The following is a description of a gene set: studied in species Homo sapiens Hypoplasia of the corpus callosum Underdevelopment of the corpus callosum. Human Gene Set: HP_HYPOPLASIA_OF_THE_CORPUS_CALLOSUM, and this is the list of marker genes: EXOC8, MINPP1, MT-CO3, SLC5A6, NAE1, TBCK, MT-CO1, SOX2, GFER, GLI3, UNC80, ALX4, SLC25A24, CEP290, CTNNB1, SETD2, PUF60, ZBTB20, UBE3B, RMND1, TRMT10A, WLS, ASNS, TREM2 (NCBI Gene Id 54209), RALGAPA1, NF1, KCNT1, PUS3, ARID1B, PRUNE1, RNASEH2C, SETBP1, TMTC3, EXOC7, FANCB, TUBA1A, PDHX, RNASEH2A, MT-ND6, EXTL3, KIF14, YARS1, TP73, CLP1, OSGEP, ADAT3, WDR73, SAMHD1, TSEN54, WDR81, DYNC1H1, NANS, TUBB2B, EHMT1 (euchromatic histone lysine methyltransferase 1), MRPS22, C2CD3, CSPP1, EMC1, RNF13, NALCN, CACNA1I, SH3PXD2B, GBA1, SIX6, CYP2U1, ZFX, NADK2, AP4B1, TRIM8, SNF8, PIGQ, VWA3B, GLRX5, TRAPPC9, CNOT3, DPAGT1, KIAA0753, IFT52, PSAT1, WDR62, UBTF, AP4S1, WDR45B, LNPK, AFG2A, YIF1B, REPS1, ZNF148 (NCBI Gene Id 7707), ZNF462, PRPS1, TBC1D20, EIF2AK2, ZMIZ1, YY1, POU3F3 (POU class 3 homeobox 3), RAB3GAP1, AFG2B, VPS50, AIFM1, TAF1, DHCR7, CDKL5, PPFIBP1, PI4K2A, FDXR (ferredoxin reductase), RTTN, GCSH, PSAP, CUL4B, PDHB, KIF26A, KMT2D, RB1, UBA5, DARS2 (NCBI Gene Id 55157), TGFB1, GLYCTK (glycerate kinase), MT-TS2, ASXL1, BRF1, FA2H, ATL1, SPG21, AIMP2, FBXW11, AMPD2, CACNA2D1, ACBD6, KCNA1, HPDL, APC2, MAPKAPK5, HACE1, MED12L, CTNNA2, RNU4ATAC, RSPRY1, MOCS1, SLC35B2, MAF (MAF bZIP transcription factor), NFIX, DDX3X, FDFT1, CNTNAP1, KIF5A, RERE, RNU4-2, SCN2A, ZEB2, GRIN1, HK1, GBA2, NR2F1, TBCE, AP4E1 (NCBI Gene Id 23431), PGAP1, EXOSC1 (exosome component 1), PPP1R15B, MT-TL1, CDK13, SLC4A10, TRAPPC6B, DIAPH1, RNU7-1, RAC1 (NCBI Gene Id 5879), ATP6V1A, NUP188, DARS1, COG6, FRMPD4, ARFGEF2, ADARB1, TAF2, KMT2C, TUBGCP2, NHLRC2, SIN3A, TMX2, IGF1R, USP9X (ubiquitin specific peptidase 9 X-linked), KATNB1, PIGU, KCNQ2, EPRS1, PAH, COG2, TOE1, RAI1, USP7, WBP4, SLC6A9, EARS2, KDM5A, SMARCE1, AXIN1, KIAA0586, DDHD2, PCNT (NCBI Gene Id 9346), NT5C2, TMEM106B (NCBI Gene Id 54664), QARS1, ALG2, ZFR, KAT8, ARHGAP31, AKT3, DCX, SHOC2, IFT27, SVBP, SRPX2, SEPSECS, GNAO1, MAP1B, FANCD2, SON, TECPR2 (tectonin beta-propeller repeat containing 2, NCBI Gene Id 9895), PHGDH, GPSM2, SLC1A4, BCOR, KDM6A, PCGF2, PTPN23, VPS53, ARX, FAT4, VPS51, PIK3R2, GFM2 (GTP dependent ribosome recycling factor mitochondrial 2), GJC2, AP3B2, COASY, MTRFR, KCNT2, MT-CO2, POGZ, RUSC2, SPTAN1, ADNP, IFT140, PARS2, EBP, MT-TW, SMG9, HIVEP2, MFSD2A, PDE6D, KIFBP (kinesin family binding protein), CEP120, YWHAE, NONO, NKX6-2, HS2ST1, OTUD5, FRA10AC1, FIG4, EXOC2, CLCN4, PLAA, TOGARAM1, PCLO, PIGG, WAC, COPB2, MED25, COX7B, LSS, KIF7, PNKP, SLC6A8 (NCBI Gene Id 6535), SCN3A, DNA2, GRIN2A, TRAPPC14, HUWE1, VARS1, SNIP1, MTOR, POMT2, GRIA3, KIF5C (kinesin family member 5C), MT-TH, RAB3GAP2, FGFR1, NARS1, VPS11, KIDINS220, GFM1, NARS2, TREX1, EIF2S3, ZFYVE26, MT-ND1, CCDC174, MEF2C, ERLIN2, STAMBP, NFIA, BRAT1, SLC32A1, NOVA2, MOCS2, SSR4, ZNHIT3, ATP9A, GRIA4, SPG11, PITX1, MT-ND5, PAFAH1B1, WDR26, MID1, SLC1A2, SCN1B, DCHS1, KDM5B, MAPRE2, ARSI, POLR2A, POLR3B, PAX6, TSEN2, POLG2, NEXMIF, LARGE1, UGP2, CARS1, MT-TQ, PLPBP, ERMARD, PPP1R21, PDHA1, LMNB1, GRM7, ADAR, NFU1, TTI2, PIGA, AP5Z1, KDM1A, AHCY, HNRNPK, PRMT7, PIGP, GAD1, FBXL4, MACF1, TUBB2A, NEUROD2, TMEM237, TMCO1, GOT2, CNP, ACTL6B, IBA57, TARS2, RARS1, RAB18, MTHFS, GMPPB, RNASEH2B, HIC1, ASXL3, SHMT2, RHOBTB2, CCDC88A, SCAF4, ASPM, TUBB3 (tubulin beta 3 class III), AP4M1, NRROS, FGFR3, TSEN34, MYCN, PIGB, PPP2R1A, AHDC1, FKRP, IFIH1, EXOSC8, ACO2 (NCBI Gene Id 50), UBE3A, TCF4 (NCBI Gene Id 6925), PLCB4, CRIPT, HSD17B4, LSM11, OCA2, CRPPA, ALDH6A1, SACS, TUBB (NCBI Gene Id 95295, tubulin beta class I), KIF2A, TBCD, GABRB1, MAPK8IP3, WWOX, RAC3, MT-TF, CARS2, TYROBP, POLR1C, MT-ND4, CASK, DOCK7, TSEN15, PGAP2, ALG12, ARNT2, SOX3 (SRY-box transcription factor 3), GABRA5, POLR3GL, BUB1B, SLC25A22, FKTN, OTUD6B, PRKDC, ALDH7A1, CHMP1A, CIT, DMXL2, TRRAP, COG4, CNOT1, STXBP1, STAG2, ATN1, BICD2, ANKRD11, LAMB1, DDX6, ZSWIM6, DYNC1I2, WT1, U2AF2, DYRK1A, NDE1, EFNB1, DAG1, POMT1, CDK10, NEDD4L, SIK1, NDUFA2, GLUL, CDC42, L1CAM, MOGS, KCTD7, RORA, FLNA, BRD4, CTU2, SLC35A2, HNRNPR, GPT2, VARS2 (NCBI Gene Id 57176), SLC25A10 (NCBI Gene Id 1468), POLR3A, ATP13A2, ACER3, HTRA2, COG7, NMNAT1 (NCBI Gene Id 64802), LONP1, PPP2CA, SMC1A, FOXG1, RELN, MBTPS2, GTPBP2, KCNK4, ATP6AP2, VAMP2, ALG3, ALG8, FLCN, PIGN, TBC1D23, IER3IP1, KANSL1, PYCR2